The following is a description of a gene set: Any process that modulates the frequency, rate or extent of action potential creation, propagation or termination in a cardiac muscle cell contributing to the regulation of its contraction. Mouse Gene Set: GOBP_REGULATION_OF_CARDIAC_MUSCLE_CELL_ACTION_POTENTIAL_INVOLVED_IN_REGULATION_OF_CONTRACTION species: Mus musculus, and this is the list of marker genes: Hcn4, Cav3, Akap9, Rangrf (RAN guanine nucleotide release factor), Atp2a2, Fgf13